Given this list of marker genes TNRC6C, TNRC6B, MOV10, AGO3, MIR20B, VAPA (NCBI Gene Id 9218), MIR19A, MIR19B2, MIR106B, AGO1, MIR17, AGO2, CNOT6L, MIR106A, MIR19B1, AGO4, TNRC6A, MIR20A, PTENP1, here is a description of the gene set: part of: Regulation of PTEN mRNA translation Coding and non-coding RNAs can prevent microRNAs from binding to PTEN mRNA. These RNAs are termed competing endogenous RNAs or ceRNAs. Transcripts of the pseudogene PTENP1 and mRNAs transcribed from SERINC1, VAPA and CNOT6L genes exhibit this activity. SERINC1 mRNA will be annotated in this context when additional experimental details become available. Reactome Pathway: Competing endogenous RNAs (ceRNAs) regulate PTEN translation species: Homo sapiens